The following is a description of a gene set: Human Gene Set: GOCC_PHAGOPHORE_ASSEMBLY_SITE_MEMBRANE studied in species Homo sapiens A cellular membrane associated with the phagophore assembly site., and this is the list of marker genes: ATG5, WIPI1, ATG2A, RB1CC1, ATG12, STBD1, WDR45, ATG16L1, ATG9B, ULK2, RAB7A, WIPI2, RAB33B, ULK1, ATG16L2, ATG2B, ATG14 (autophagy related 14), ATG9A (NCBI Gene Id 79065), WDR45B, ULK3, RAB1B, ATG13